Given this list of marker genes Prpf31, Coil, Ccnt1, Tex16, Ro60, Larp7, Snrpa1, Lsm3, Rbm7, Hexim2, Lsm4, Celf3, Toe1, Rnpc3, Ncbp2, Snrpa, Ddx39b, Snu13, Snrnp35, Lsm11, Rbm22, Mepce, Hnrnpu, Cdk9, Snrnp70, Snrpc, Lsm10, Ddx21, Snrpd3, Tut1, Prpf8, Isg20, Prpf4, Snrpb2, Eftud2, Sf3b3, Eif5a, Larp7-ps, Gemin5, Ccnt2, Sart3, Rbm41, Mettl16, BC005624, Hexim1, here is a description of the gene set: Mouse Gene Set: GOMF_SNRNA_BINDING Binding to a small nuclear RNA (snRNA). species: Mus musculus